Given this list of marker genes Prag1, Oas3, C1qbp, Zdhhc21, Isg15, Shmt2, Hdgf, Exosc9, Cycs, Mrto4, Nifk, Gzmb, Dkc1 (dyskeratosis congenita 1, dyskerin), Eif4a1, Gcsh, Rpf2, Pfn1, Cct8, Mrpl17, Ppa1, Mbtps1, Actg1, Pwp1, here is a description of the gene set: from publication Cui A, Huang T, Li S, Ma A, Pérez JL, Sander C, Keskin DB, Wu CJ, Fraenkel E, Hacohen N (PMID 38057668) Cytokines mediate cell-cell communication in the immune system and represent important therapeutic targets. A myriad of studies have highlighted their central role in immune function, yet we lack a global view of the cellular responses of each immune cell type to each cytokine. To address this gap, the authors created the Immune Dictionary, a compendium of single-cell transcriptomic profiles of more than 17 immune cell types in response to each of 86 cytokines (>1,400 cytokine-cell type combinations) in mouse lymph nodes in vivo. A cytokine-centric view of the dictionary revealed that most cytokines induce highly cell-type-specific responses. For example, the inflammatory cytokine interleukin-1β induces distinct gene programmes in almost every cell type. A cell-type-centric view of the dictionary identified more than 66 cytokine-driven cellular polarization states across immune cell types, including previously uncharacterized states such as an interleukin-18-induced polyfunctional natural killer cell state. Mouse Gene Set: CUI_NK_CELL_IL33_RESPONSE_UP Genes positively differentially expressed in cell type: NK cell upon treatment with cytokine: IL-33 in mouse lymph nodes in vivo. studied in species Mus musculus